Given this list of marker genes SCGB1C2, SAT2, EMC6, SHPK, KIF1C, DNAH2 (NCBI Gene Id 57637), ENSG00000212206, ATP1B2, ENSG00000262003, SPATA22, RNF222, ANKFY1, OR1E1, SNORD91A (NCBI Gene Id 692207), MIR4520-2, ENSG00000283025, ZFP3, HES7, TNFSF12-TNFSF13, MED11, OR3A2, OVCA2, GPS2 (G protein pathway suppressor 2), CLUH, RN7SL33P, RILP, SERPINF2, MYBBP1A, RNF227, MIR6864, TMEM220-AS1, CTNS, DHX33, CAMTA2, MCUR1P1, MIR4520-1, SENP3, MIR3183, SMTNL2, PFAS, EIF4A1, RAP1GAP2, ENSG00000228133, MFSD6L, C17orf107, DHRS7C, MRM3, TEKT1, RPH3AL, NLRP1, CHRNB1, MIR497HG, MYH8, SLC52A1, GGT6, ATP6V0CP1, RNASEK, P2RX5, CXCL16, ENSG00000284837, RPL26, TMEM88, GLTPD2, SPEM1, PIK3R6, MIR195, OR1A1, RNF167, PIK3R5-DT, ELP5, OR1E2, PFN1, ENSG00000266279, OR1D2, PITPNA-AS1, SERPINF1, SPNS2, ITGAE, TLCD2, GLOD4, MNT, ALOX12P2, PRPF8, KIF1C-AS1, TMEM102, OR1G1, RFLNB, STX8, MYH13, TMEM220, ENSG00000262884, SCARNA21, ENSG00000286190, GUCY2D, RN7SL608P, ALOXE3, SENP3-EIF4A1, TAX1BP3, ABR, DOC2B, TMEM256, TNFSF13, VPS53, RPL19P18, BORCS6, TMEM95 (NCBI Gene Id 339168), SNORA67, SDHCP5, TIMM22, SCIMP, ALOX15P1, PLD2, C17orf114, ENSG00000262966, PLSCR3, P2RX5-TAX1BP3, SCO1, TXNDC17, HNRNPA1P16, ENSG00000277613, UBE2G1, OR1P1, RPL23AP73, MPDU1-AS1, OR1E3, MIR6883, SPEM3, CLDN7, ARRB2, RNA5SP434 (RNA, 5S ribosomal pseudogene 434), FGF11, TLCD3A, AIPL1, KCNAB3, YWHAE, SPEM2, METTL16, SPNS3, NEURL4, ADPRM, MYH4, ACAP1, PIK3R5, RTN4RL1, INPP5K, ODF4, LINC00324, MIS12, RPL29P2, RPS4XP17, ENSG00000286356, DHX33-DT, SCARF1, KIAA0753, TMEM256-PLSCR3 (TMEM256-PLSCR3 readthrough (NMD candidate)), AURKB, SHBG, CYB5D2, RANGRF, RABEP1, ASGR1, RCVRN, PELP1, MYO1C, ALOXE3P1, LINC01975, C17orf100, PELP1-DT, OR1AC1P, SNORA48, RPA1, VAMP2, TP53, PHF23 (NCBI Gene Id 79142), SLC2A4, SLC16A11 (solute carrier family 16 member 11, NCBI Gene Id 162515), VMO1, NUP88, TM4SF5, RNA5SP435, DBIL5P, MIR22, ATP2A3, NPM1P45, ZBTB4 (NCBI Gene Id 57659), PSMB6, ZMYND15, FXR2, ZNF232, CYB5D1, LIAT1, ALOX15B, WRAP53, MIR4314, ZNF232-AS1, OR3A1, SOX15, SLC13A5, SNORD91B, MIR6865 (NCBI Gene Id 102465522), PITPNM3, ENSG00000241525 (novel transcript, antisense to C17orf97), MYHAS, MINK1, ENSG00000285593, ZNF594, HIC1, MAGOH2P, SLC25A35, MIR497, CFAP52, SLC25A11, SGSM2, EIF4A1P9, BCL6B, MIR324 (NCBI Gene Id 442898), RN7SL774P, CRK, NCBP3, RPL7AP64, ASPA, XAF1, RYKP1, PIMREG, GLP2R (NCBI Gene Id 9340), SNORD118, OR1R1P, DPH1 (NCBI Gene Id 1801), GP1BA, ALOX12, SAMD11P1, NXN, ENSG00000282936, OR3A4P, ZNF594-DT, MYH2, SLC35G6, EIF5A, NDEL1, SGSM2-AS1, ENO3, RNU7-43P, RN7SL624P (RNA, 7SL, cytoplasmic 624, pseudogene), USP43, TRPV1, RNASEK-C17orf49, RPS27AP1, C1QBP, SRR, RPH3AL-AS2, RPL21P125, PPIAP52, SPNS2-AS1, GEMIN4 (NCBI Gene Id 50628), PRAL, WSCD1, NTN1, ALOX15, SPICP3, TRAPPC1, SMYD4, LINC02091, ENSG00000225084, ASGR2, ARHGEF15, ZFP3-DT, RNU6-955P, GAS7, CD68, MIR1253, DERL2, CCDC92B, EFNB3, KCTD11, MIR22HG, OR3A3, ENSG00000302010 (novel transcript), LINC02887, SLC16A13, YBX2, NAA38, ENSG00000299154, BTF3P14, SPAG7, CNTROB, TRPV3, MYH3, TSR1, C17orf49, DPH1-AS1, SPDYE4, CCDC42, SMG6, DVL2, SNORD10, TNFSF12, TXNP4, INCA1, ZZEF1, MIR4521, MYH1, GSG1L2, CAMTA2-AS1, RN7SL105P, RPH3AL-AS1, RN7SL784P, HASPIN, LINC01996, KRBA2, OR1A2, KDM6B, POLR2A, TRARG1, CAMKK1, CHD3, CTNS-AS1, BHLHA9, MPDU1, MFSD1P1, OR1D4, TNK1, NLGN2, CLEC10A, MYH10, WDR81, CTDNEP1, ABR-AS1, P2RX1, SMG6-IT1, RNU6-1264P, USP6, MIR132, RPAIN, PITPNA, PAFAH1B1, FBXO39, ALOX12B, ENSG00000262231, OR1D5, OR1D3P, TMEM107, GABARAP, CHRNE, SLC43A2, MED31 (mediator complex subunit 31), DLG4, CTC1, MIR212, ACADVL, MIR6776, PER1, here is a description of the gene set: Human Gene Set: chr17p13 studied in species Homo sapiens